The following is a description of a gene set: Human Gene Set: WP_PHOTODYNAMIC_THERAPYINDUCED_NFE2L2_NRF2_SURVIVAL_SIGNALING studied in species Homo sapiens Photodynamic therapy-induced NFE2L2 (NRF2) survival signaling, and this is the list of marker genes: ABCC2, MAPK11, ABCG2, NQO2, HMOX1, CES1, MAPK14, NQO1, MAPK13, JUN, GCLC, GSTP1, KEAP1, SRXN1, FOS, NFE2L2, ABCC3, MAPK12, GCLM, ABCC4, EPHX1, MAPK8, ABCC6